Given this list of marker genes ABCC10, ABCC5, ABCC4 (ATP binding cassette subfamily C member 4 (PEL blood group)), ABCC2, ABCC11, ABCC3, CFTR, ABCC9, ABCC6, ABCC1, here is a description of the gene set: Human Gene Set: GOMF_ATPASE_COUPLED_INORGANIC_ANION_TRANSMEMBRANE_TRANSPORTER_ACTIVITY Enables the transfer of a solute or solutes from one side of a membrane to the other according to the reaction: ATP + H2O + inorganic anion(out) = ADP + phosphate + inorganic anion(in). species: Homo sapiens